The following is a description of a gene set: A morphological abnormality of the mouth in which the angle of the mouth is downturned. The oral commissures are positioned inferior to the midline labial fissure. Human Gene Set: HP_DOWNTURNED_CORNERS_OF_MOUTH species: Homo sapiens Downturned corners of mouth, and this is the list of marker genes: PACS2, EXT2, NEXMIF, ZC4H2, WNT5A, PGAP3 (post-GPI attachment to proteins phospholipase 3), CSNK2B, DPH5, MASP1, SMC3 (structural maintenance of chromosomes 3), SRCAP, NPAP1, GNB2, BRPF1, AFF4, TRMT10A, KAT6A, CACNA1A, DYRK1A, HOXB1, TWIST2 (twist family bHLH transcription factor 2), BRD4, HNRNPK, DPF2 (NCBI Gene Id 5977), COLEC11, HDAC8, TELO2, POLR3A, PRKAR1B, TCF20, PIGO, PPP1R15B, TBC1D24, HS6ST2, KCNH1, STAC3, SLC1A3, SMC5, KCNMA1, UBR1, UBE2A, ATP1A3, PIGL, FOXP1, IGF2, NARS2, POLA1, CACNA1C, MED12L, PACS1, MEF2C, GPC4, PIGV, NDN, NOTCH2, PIK3R1 (phosphoinositide-3-kinase regulatory subunit 1), SETD5, PIGY, NTNG2, H4C11, TRAPPC9, PIGA, PLOD3, CTBP1, CDK5, H3-3A, CRELD1, HERC2, PGAP2, ABL1, MKRN3, PHF21A, KAT8, PIGG, KMT2D, AFF3, TBL1XR1, SCNM1, MED13L, RAB18, ZPR1, DVL1, RTL1, ZMYM2, TAF6, CDC42, KDM4B, COLEC10, DNAJC21, PWRN1, DCHS1, INTS1, CAMTA1, LEMD3, SNORD115-1, SC5D, SNRPN, FZD2, MEG3, MBD5, SMARCD1, TRIP12, HDAC4, WAC, KDM1A, GRB10, PIGW, RNU4-2, DHX37, GMPPA, GK, RLIM, ZBTB20, RAI1, CPLX1, KIF7, CDK13, CHRNG, EBF3, PIGQ (NCBI Gene Id 9091), ALX4, TASP1, MYMX, GCK, FAT4, STAT3, FBXO11, EFEMP1, PCLO, ROR2, DVL3, EIF2S3 (NCBI Gene Id 8422), CCDC47, GLI2, NELFA, NSD2, KIAA0753, OCA2, PIGU, HMGA2, INS, PDX1, C1GALT1C1, RAD21, HACE1, CDH11, CNOT3, FGFRL1, MSL3, SHMT2, PWAR1, SON, EHMT1, NXN, POGZ, NOVA2, DLK1, MAFB, SMC1A, SNORD116-1, PIGT, PCGF2, ZNF407, LMBR1, SIM1, ASH1L, MAGEL2, WDR4, ABCC8, H4C5, KIF15, ATP1A2, RNU4ATAC, LETM1, PRR12, WDR37, KCNJ11, NIPBL, ZSWIM6, ATP6V1B2, EEF1A2